The following is a description of a gene set: Human Gene Set: FAN_OVARY_CL0_XBP1_SELK_HIGH_STROMAL_CELL species: Homo sapiens Most stromal cells from selectable follicle C clustered in CL1 (Fig. 3a). Although stromal clusters (CL0, CL1) showed high expression of GNL3 and ARID5B (Fig. 8d), CL0 expressed high levels of XBP1 and SELK (Fig. 8e), both involved in endoplasmic reticulum (ER)-stress-induced apoptosis, whereas CL1 expressed high levels of GPRC5A and TNFRS12A (Fig. 8f). from publication Fan X, Bialecka M, Moustakas I, Lam E, Torrens-Juaneda V, Borggreven NV, Trouw L, Louwe LA, Pilgram GSK, Mei H, van der Westerlaken L, Chuva de Sousa Lopes SM (PMID 31320652), and this is the list of marker genes: YBX1, CHMP4B, RSL24D1, HSP90AB1, EEF1D, PABPC1, DNAJB6, RPLP1, EIF2S2, SNHG8, RPS4X, RPL11, BTF3, SELENOK, SNHG7, NUPR1, IFRD1 (interferon related developmental regulator 1), RSL1D1, DCN, RPL10A (ribosomal protein L10a), RPS18, CLEC2B, HSPD1, PNRC2, FGF7 (NCBI Gene Id 82955), EIF4E, PEG10, RPS15, RACK1, SAR1A, RPL31, LUM, EIF1, FAU, PTGES3, RPL13, RPL36A, ZFAS1, EIF5, RPL36AL, IQCG, RPS13, RPS3A, MAPRE1, RPL38, RPS9, HSP90B1, CNN3 (NCBI Gene Id 1266), RBMX, C11orf96, RPS19, NPM1, SELENOS, RPS27A, H2AZ1, TMED2, RPS23, FHL2, RPL8, RPL17, SDC2, EPB41L4A-AS1, CTNNAL1, ARID5B, EIF3E, NFE2L2, VAPA, RPL18, PNRC1, SPTSSA (NCBI Gene Id 171546), RSRC2, RPS3, FBL, RPL35A, RPL13A, RPL36, PTP4A1, INSIG1, GNL3, SERP1, MORF4L2, RPL10, RPL21, HBP1, RPL12, MEG3, RPS24, RPL6, RPS8, HES1, RPL5, RPL26, HERPUD1, RPL24, ATP1B1, HSPH1 (NCBI Gene Id 9835), RPL9, RPLP2, SRSF10, NEAT1, CEBPB, RPL32, SAT1, UBE2B, RPL39, NACA, CIRBP, RPS6, RPL41, PAPOLA, STAR, IGFBP5, CYCS, RPS2, EIF4A2 (NCBI Gene Id 63124), RPS14, SLC40A1, HSPA9, RPL15, CCNG1, STK17A, RPL34, RPL30, RHEB, RPS27, XBP1, ST13, RPL14, RPS5, HSPA5, EIF1B, RPL18A, RPS12, RPL7, PTMA, SNHG32, RPL3, DDX21 (NCBI Gene Id 9188), RPL23A, ERRFI1, DNAJB9, PFDN5, ATP1A1